Given this list of marker genes Nfix, Foxp3, Pcdha2, Kcnj6, Crispld2, Ube3a, Shisal1, Aasdhppt, Pcdha4, Cyp1b1, Spef1l, Pcdha11, Mbd6, Sprr1a, Camkv, Raver2 (ribonucleoprotein, PTB-binding 2), Arsg, Bahcc1, Rtp3, Hmx3, Skp1, Tceanc2, Afmid, Rock2, Actb, Atp1a3, Meaf6, Per3, Atxn1, Pcdha8, Prkn, Pgap3, Mast4, Sipa1l3, Pcdha7, Hoxd13, Ost4, Slf2, Zfp131, Mcl1, Mecp2, Pipox, Maf, Zbtb7a, Mtus1 (mitochondrial tumor suppressor 1), Hnrnpab, Spink2, Pcdha9, Setd1b, Mapk11, Pcdha3, Nfic (nuclear factor I/C), Ptp4a2, Sncb, Pcdhac2, Fam120a, Prpf38b, Col1a1, Lrrtm4, Pcdha12, Adora3, Fxr2, Pcdha6, Map3k20, Eif4b, Kcnc3, Pym1, Klf12, Greb1, Asap1, Mtrfr, Pcdha1, Cnot2, Nhsl2, Mapkap1 (mitogen-activated protein kinase associated protein 1), Dlx3, Sorbs1, Snx12, Pcdha5, Pcdhac1, Fgf18, Zfp708, Nectin1, Cradd, Pcdha10, here is a description of the gene set: studied in species Mus musculus Genes predicted to be targets of miRBase v22 microRNA mmu_miR_6980_5p in miRDB v6.0 with MirTarget v4 prediction scores > 80 (high confidence targets). Mouse Gene Set: MIR_6980_5P from publication Chen Y, Wang X (PMID 31504780)